Given this list of marker genes TSG101, ACTL6B, WBP2, LMO3, TRIM5, MAML2, ENO1 (NCBI Gene Id 81977), TAF6, HMGB1, KDM2A, EN2, SCAI, LIMD1, DMAP1, MIER1, N4BP2L2, ANKRD1, ATXN7L3, TLE5, FHL5, SIRT1, JUP, RERE, KCTD1 (potassium channel tetramerization domain containing 1), NME2, TLE6, JADE1, CCDC62, HIPK2, HCFC2, KMT5A, DDX17, WWC1, AEBP2, ARID3A, MED27, PUS1, BCL11A, LMO1, DOT1L, UXT, CENPJ, CBFB, CAMTA1, UTF1, ZNF366, NRG1, TMF1, PFDN5 (prefoldin subunit 5), ABT1, RAD54L2, FLYWCH1, MED13L, ACTN2, DDX1, MED16, NUCKS1, MED11, WWOX, SMARCD2, NPM1, RIPK3, PARP14 (poly(ADP-ribose) polymerase family member 14), MAK, CAMTA2, GON4L, UBE2L3, PRMT2, ACTL6A, KAT6A, BRDT, TCERG1L (NCBI Gene Id 256536), PHB1, ZNF541, PRKCB, MED20, SF1, CRYM, CITED2, NCOA3, RBM14, CASP8AP2, TAF6L, PRDM8, IRF4, ACTN1 (NCBI Gene Id 87), TRIM21, SFR1, NSD1, PRKN, CNOT2, ZNF653, IRF2BP1, ZNF354B, TBL1XR1, MED12L, PPP1R13L, MIER3, TBL1X (NCBI Gene Id 6907), FHL3, CIR1, POU2AF1, SAP18, SETD3, RBCK1, ZBED1, TAF9, USP22, KMT2D, SAP30, PIAS2, CDYL2, USP21, CRTC2, BIRC2, NPAT, KDM4C (NCBI Gene Id 23081), RIOX2, LPXN, SMYD1 (SET and MYND domain containing 1), TOX2, ARID5B (NCBI Gene Id 84159), ID4, TRIP4 (thyroid hormone receptor interactor 4), ZMIZ2, PAGE4, MYBBP1A, MAML1, TRIM27, DAXX, KDM5A, CDY2A, CCDC124, VGLL2, KMT2C, MUC1, HELZ2, PAWR, BCL10 (NCBI Gene Id 8915), BCL3, SERTAD1 (SERTA domain containing 1), QKI, PARP10, ZMYND11, DDIT3, PHF24, LPIN1, SRCAP, PHF12, ARL2BP, BTAF1, RCOR3, CTBP2 (NCBI Gene Id 87435), EZH1, MED30, ZMIZ1, AKIRIN2, MED8, PPRC1 (PPARG related coactivator 1), ATF7IP, BRD7, RNF20, NCOA4, MED4, MED19, HCFC1, ZNF451, MECP2, RUVBL1, WDR77, MAP3K10, RRP1B, SIAH2, SMARCD1, MLIP, SUB1, BUD31, TRIM25 (tripartite motif containing 25), HSBP1, TLE1, POU2AF2, BCL9L (NCBI Gene Id 283149), PARP15, MIDEAS, TRIP11, DDX54, TRRAP, CITED1, TRIM13, LMO2, PA2G4, TRIM32, KAT5, MED7, ZFPM2, TRIM15, TADA2B, TP53BP1, TRIB3, PIAS1, KAT2B, HMGA2, NFKBIZ, SS18L1, SIN3A, JAZF1, ZIC3, PARK7, YEATS2, DNMT3A, KDM3A, TLE2, BTG2, CRTC3, PIAS3, MED17, TLE7, RUVBL2, NRIP1, MED12 (mediator complex subunit 12), ACTN4, RBPMS, SLC30A9, MED1, ZNF764, CTBP1, PPARGC1A, COPS2, MED29, MAML3, MED15, ZMYND8, XPC, TDRD3, CDY2B, KMT2E, DHX9 (NCBI Gene Id 3450), KDM1A, ABL1, CNOT6, KCTD15 (potassium channel tetramerization domain containing 15), PBXIP1, RUNX1T1, BEND6, SMARCC2, KDM5B, EOMES, PRDM16, TRIM31, AIP, TGFB1I1, MTA1, TRIM37, BASP1, MYT1L, TRIM38, CHD4, CRTC1, NUP98, UBE3A, PHF10 (PHD finger protein 10), ID2, TADA3, MED21, APBB1, BRCA1, HDAC3, ID3, SUPT20HL2, SFMBT1, BRD8, TOB2, ZXDB, BRD4, WTIP (WT1 interacting protein), ID1, MED31, ING4, WBP2NL, AKIRIN1, WWTR1, BMAL1, TBX6, RNF14, SUFU, PIR, TRIM8, SND1, KAT7, NACA, FOXA2, NFKBIB, NCOA7, NCOA6, ZXDA, SERTAD2, VGLL1, EWSR1, SMARCA2, PDLIM1, CBX4, MAGED1, HIF1AN, TBXT, NIBAN2 (niban apoptosis regulator 2), HMGA1, PSMC3IP, NCOA5 (NCBI Gene Id 57727), SP100, MAMSTR, NOC2L, PPARGC1B, HDAC7, PER2, HDAC1, HSPA1A, TLE3, SUPT20H, TADA2A, YAF2, DNMT3B, TCERG1, ATN1 (atrophin 1), NR0B2, TADA1, BCL9, AASS, NAB2, SMAD7, DNAJB1, CDYL, HSBP1L1, EZH2, PSMD9, PKM, CCND1, SIRT6, CIITA (class II major histocompatibility complex transactivator), ASAH1, SPEN, ARRB1, MED14 (NCBI Gene Id 9282), MED9, PQBP1, CBFA2T3, ACSS2, CREG1, PML, CTNNB1, ENY2, ARID1B, LMO4, EID1, HYAL2, MED26, CBFA2T2, TRIM52, JUND, ATF7IP2, TOX3, HMGB2, PARP9, CEBPZ, YAP1, SRSF2, MID2, MIER2, IRF2BP2, PHF2, MTDH, ASXL1, SUPT3H, ARID1A, EDF1, NR0B1, MED24, NOTCH1, SDR16C5, MTA2, LPIN2, SETD4, JMY, URI1, FUS, SNW1, HDGF, PEX14, TRERF1, DYRK1B, GMNN, CD274, C1D, MED13, DTX1, ARID5A, CARM1, NUPR1, FBXL19, TRIM14, WNT3A (Wnt family member 3A), TRIM28, MAD2L2, MRTFB, CDCA4, LCOR, TBL1Y, CITED4, KDM2B, TAF5L, FHL2, APEX1, SUPT20HL1, TAF11, KAT6B, SETD5, LDB2, PTPN14, RYBP, MED18, ZFPM1, HR, PCBD1, KDM7A, NCOA1, CCAR1, RBBP8 (RB binding protein 8, endonuclease), CDY1, TAF9B, LDB1 (NCBI Gene Id 8861), TAF12, LPIN3, MED22, NCOA2, MMS19, KAT8, ZXDC, TACC1, MRTFA, GPS2, USP16, COPS5, AJUBA, TAF15, ARGLU1, MED6, THRAP3, IL31RA, TSC22D1, CALCOCO1, ELANE, PSIP1, PHF8, MTA3, MYCBP, PMF1, DCAF6, DYRK1A, NIPBL, ZNF410, SFMBT2, SIN3B, FOXP3, FIZ1, BCOR, SS18, RB1, HNRNPU, NFE4, TLE4, CREBBP, JMJD1C, BCLAF1, PRMT5, SMARCC1, WNT4, FOXH1, DPF2, PKN1, SSX1, RBFOX2, KAT2A, EID2, SUPT7L, TRIP13, TRIM62, TRIM22, HDAC9, MED23, MED10, NAB1, GTF2A1L, SMARCA4, CNOT9, TDP2, EID2B, BTG1, KDM3B, CDY1B, RCOR2, LMCD1, C1QBP, MYOCD, EP300, RLIM, ARK2N, BCORL1, POU2AF3, SAP30L, TDG, NFKB1, BCLAF3, NCOR2, SRA1 (NCBI Gene Id 10011), SSBP3, PIAS4, NCOR1, MYSM1, TRIM24, RAP2C, TOB1 (NCBI Gene Id 10140), TCP10L, RCOR1, HIRA, SMARCB1, RALY, SMARCE1, SMARCD3 (SWI/SNF related, matrix associated, actin dependent regulator of chromatin, subfamily d, member 3), CNOT7, here is a description of the gene set: studied in species Homo sapiens A transcription regulator activity that modulates the transcription of specific gene sets via binding to a DNA-binding transcription factor at a specific genomic locus, either on its own or as part of a complex. Coregulators often act by altering chromatin structure and modifications. For example, one class of transcription coregulators modifies chromatin structure through covalent modification of histones. A second class remodels the conformation of chromatin in an ATP-dependent fashion. A third class modulates interactions of DNA-bound DNA-binding transcription factors with other transcription coregulators. Human Gene Set: GOMF_TRANSCRIPTION_COREGULATOR_ACTIVITY